Given this list of marker genes Slc5a12, Slc16a7, Slc16a1, Slc16a3, Slc5a8, here is a description of the gene set: species: Mus musculus Mouse Gene Set: GOMF_LACTATE_TRANSMEMBRANE_TRANSPORTER_ACTIVITY Enables the transfer of lactate from one side of a membrane to the other. Lactate is 2-hydroxypropanoate, CH3-CHOH-COOH; L(+)-lactate is formed by anaerobic glycolysis in animal tissues, and DL-lactate is found in sour milk, molasses and certain fruit juices.